The following is a description of a gene set: species: Homo sapiens Abnormality of binocular vision An abnormality of binocular vision, that is of the ability to synthesize the visual inputs from both eyes to a single image with perception of depth. Human Gene Set: HP_ABNORMALITY_OF_BINOCULAR_VISION, and this is the list of marker genes: CACNA1G, HTRA2, FGF14 (NCBI Gene Id 317685, fibroblast growth factor 14), SNCA, NAB2, HLA-DRB1, PTPN22, ERCC5, CDH23, TTC19, MEN1, KCND3, PODXL, CHAT, SYNJ1, LRP4, DKK1, CHRNB1, PRNP, ERCC2, DOK7, CHRNE, ATP1A2, TMEM240, PARK7, DARS2 (NCBI Gene Id 55157), MT-TL2, ATXN3, SCN1A (sodium voltage-gated channel alpha subunit 1), PRKN, POLG, DNAJC6, SPTBN2, ANO10, ADPRS, MAPT, SAG, HLA-DQB1, MT-TL1, TOP3A, ERCC3, SDHA (NCBI Gene Id 6389), SLC2A1, DNAJC13, HLA-B, TTR, MYO5A, RILPL1 (NCBI Gene Id 353116), VAMP1, NPTX1 (NCBI Gene Id 4884), COL13A1, SYT2, NFKB2, P4HA2, SLC25A1, TGFB1, SLC1A3, AGRN, CHRND, VPS35, SAMD9L, MUSK (NCBI Gene Id 4593), MGME1, SLC5A7, AIP, KCNA1, SLC18A3 (solute carrier family 18 member A3), CACNA1A, STAT6, SNAP25, MYO9A, RAPSN, SCN4A, PINK1, AK9, EIF4G1, GBA1, PRRT2, TYMP, SERPINI1, ERCC4, MT-TN, TPP1, NF2, CHRNA1, GRK1, UCHL1, NOP56, VPS13C, GIGYF2, LRRK2